Given this list of marker genes ZNF609, ADCY6, TPM4, EIF4A2, ARID3B, SLC9A5, BYSL, KRT78, QKI, PRR13, ZBTB39, PHF8, TAFA3, GFAP, SRCAP, NPTXR, PCGF2, MAP3K14, LIMK2, PRR23C, PLA2G2F, NCALD, MZT2B, PRKD2, KIF24, MED29, TRIM66, PLCH1, SCAMP4, MED9, PPP1R9B, GIGYF1, NFATC4, USF2, ACE, TET3, AMACR, GGA3, SAMD10, UBL4A, NCAM1, SP7, APOBEC3C, WDTC1, ZNF512B, TMEM63A, PDGFRB, PPP1R10, EXTL3, POU2F2, AIF1L, SLC25A23, RASD2, LMX1B, PHF24, IQSEC2 (NCBI Gene Id 4382), PXN, DNAJC11, MTCL2, SZT2, FAM53C, PKP1, TEAD3, SLC6A9, PPARA, GNAI2, GIPC3, GGA1, LEF1, RNF185, CERCAM, CCDC97, ADRB3, PAX5, NECTIN1, MECP2, DIAPH1, FXN, URM1, ORAI2, PPP2R1A, MYPOP, HIP1, SLC23A3, APOBEC3D, ZDHHC3, TMEM184A, MPZ, ZNF619, TANC2, TTBK1, ANKS6, TSPAN11, GRK6, CDT1, IQSEC3, BEGAIN, CALR, ERF, TMEM255A, ZFAT, CD83, ZNF831, FBXO41, RFX1, MICAL1, RXRB, PDXK, N4BP2L2, NPRL3, SEH1L, ANKFY1, TNS1, NEUROG1, KSR2, KIF21B, CACNB1, ABR, MPRIP, KCND1, FOXE1, HMG20A, PRDM16, L1TD1, EFR3B, MIDN, AAK1, TSPAN18, PACS1, TMEM127, ACTR1B, TTYH3, L1CAM, APC2, AGAP1, NRSN1, FNDC4, CCDC93, NGFR, TBX10, COLCA1, CCND2, ZNF827, CPEB4, BANF1, CORO2B, FGF1, KCNQ2, MAST3, KCNC1, PAAF1, DMWD, ADARB1, EVI5L, KCNJ10, TRAM2, GPRC5B, C14orf132, SRRM2, SFRP2, TP53INP2, FGF19, ARL6IP4, CDH4, ST3GAL1, ST18, LMOD1, CISH, CRIP3 (NCBI Gene Id 401262), SIRT2, SNX20, TLN1, CD74, DVL3, ICOS, DELE1, ADCY1, EEIG1, ESPN, CLIP1, METTL6, KCNK3, TOM1L2, PITPNM2, ASB6, NMNAT2, DCAF8, ACTG1, ZNF516, DOK2, ZFAND3, CDK19, DBNDD1, APOBEC3F, FRMD5, RING1, HEY1, EHMT2, COA7, HEYL, ARC (activity regulated cytoskeleton associated protein), MZT2A (NCBI Gene Id 653784), ADAMTS10, GRK2, LARP1, PA2G4, SLC6A6, MUC6, SDC3, SPPL2B, ZCCHC3, PLEK2, DLX1, ATXN2L, SLC7A1, SETD5, ZBTB46, SMIM3, N4BP3, SH3TC2, MLLT1, PRAP1, RNF26, WDR48, TBCK, DMAC2, SDC1, BARHL1, CIDEB (cell death inducing DFFA like effector b), SELENON, CARNS1, STAT3, HOXC5, DES, FOXP1, TSNARE1, SLC43A2, CRTC1, COBLL1, TMEM132E-DT, ADGRA1, PIP4K2A, KRTAP10-10, RAB6B, CPLX2, BAZ2A (NCBI Gene Id 23525), STK40, UNC5B, TMUB2, MBOAT7, ZNF154 (NCBI Gene Id 7710), ACAP3, SORBS3, C4orf46, SCARA5, ZMYM3, here is a description of the gene set: from publication Chen Y, Wang X (PMID 31504780) Human Gene Set: MIR4731_5P species: Homo sapiens Genes predicted to be targets of miRBase v22 microRNA hsa-miR-4731-5p in miRDB v6.0 with MirTarget v4 prediction scores > 80 (high confidence targets).